Given this list of marker genes ADAMTSL1, NKX2-5, TSHR (NCBI Gene Id 7253), SLC26A4, TCOF1, DUOX2, KAT6B, POU1F1, POLR1D, NSDHL, LHX4, PROP1, IRS4, KMT2D, GNB2, PAX8, POLR1B, HESX1, FOXE1, TSHB, POLR1C, LHX3, GLI3, TRHR, NKX2-1, here is a description of the gene set: Aplasia/Hypoplasia of the thyroid gland Human Gene Set: HP_APLASIA_HYPOPLASIA_OF_THE_THYROID_GLAND Absence or underdevelopment of the thyroid gland. studied in species Homo sapiens